Given this list of marker genes GABBR2 (NCBI Gene Id 9568), SMC1A, PLP1, MECP2, CDKL5, NTNG1, here is a description of the gene set: Hand apraxia Human Gene Set: HP_HAND_APRAXIA Inability to perform purposeful (learned) movements with the hand upon command, even though the command is understood and there is a willingness to perform the movement. Hand apraxia includes the inability to grasp, pick up, and hold large and small objects. studied in species Homo sapiens